Given this list of marker genes ARHGAP20, ITGB2, SERPINA3, NAB1, ADORA2B, RAD51AP1 (NCBI Gene Id 10635), PCYT1A, RAB32 (RAB32, member RAS oncogene family), INSM2, EPS15, MAPK14, MMP1, LYN, SKAP2, MAP6, CAST, EDIL3, FGF12, FLT3LG, MSC, MED14, GIMAP7, H1-2, CPNE8, HYAL3, FASLG, ADD1, GNAI1, ITIH3, TNFSF8, here is a description of the gene set: Bexarotene (Targretin), is a synthetic high-affinity RXR receptor agonist with limited affinity for RAR receptors. Bexarotene has shown efficacy in a phase I/II trial of non-small-cell lung cancers. However, the chemopreventive efficacy of bexarotene has not been determined in mouse lung cancer models. In this study, we have investigated the ability of bexarotene to inhibit lung tumor progression in the mutant A/J mouse models with genetic alterations in p53 or K-ras, two of the most commonly altered genes in human lung tumorigenesis. Mice were administered vinyl carbamate (VC), a carcinogen, by a single intraperitoneal injection (i.p.) at 6 weeks of age. Bexarotene was given by gavage starting at 16 weeks after VC and was continued for 12 weeks. Although all mice developed lung tumors, only 7% of lung tumors were adenocarcinomas in wild-type mice, whereas 22 and 26% of lung tumors were adenocarcinomas in p53 transgenic or K-ras heterozygous deficient mice. Bexarotene inhibited both tumor multiplicity and tumor volume in mice of all three genotypes. Furthermore, bexarotene reduced the progression of adenoma to adenocarcinoma by approximately 50% in both p53(wt/wt)K-ras(ko/wt) and p53(wt/wt)K-ras(wt/wt) mice. Thus, bexarotene appears to be an effective preventive agent against lung tumor growth and progression. Human Gene Set: WANG_RESPONSE_TO_BEXAROTENE_DN Genes down-regulated in the mouse lung cancer model and which reverted to normal levels upon treatment with bexarotene. from publication Wang Y, Zhang Z, Yao R, Jia D, Wang D, Lubet RA, You M (PMID 16247446) studied in species Mus musculus